Given this list of marker genes LAMA1, RTN4R, PSAP, SELL (NCBI Gene Id 6402), LAMB1, LYN, SELP, EPDR1, IL2, MAG, CLIP3, here is a description of the gene set: Human Gene Set: GOMF_GLYCOSPHINGOLIPID_BINDING Binding to glycosphingolipid, a compound with residues of sphingoid and at least one monosaccharide. studied in species Homo sapiens